Given this list of marker genes ARFGEF1, TRPM7, MYL3, CXCR4, RAB3B, STXBP5 (syntaxin binding protein 5), RAB39B, GIPC1, RAB11A, SPATA6L, RAB14, MYL12B, MYL2, MYBPC1 (NCBI Gene Id 9116), KIRREL1, STXBP5L, MYL9 (NCBI Gene Id 10398), MLPH, ACTA1, NPHS1, MYH8, RHOA, TRAK1, RAB3C, CALD1, RAB11B, CORO1A, TOM1, MYBPC3, MYO19, GCSAM, MYOC, MYLK2, TRAK2, GRIA1, PYCARD, RAB6B, VEZT, RAB25, NKD2, CALML4, TRIM32, SPATA6, HAP1, NPC1L1, DMD, MYL4, IQGAP3, SHROOM4, STX1A, ARFGEF2, LARP6, LLGL2, RAB3A (RAB3A, member RAS oncogene family), LIMCH1, MYL12A, RAB8A, GSN, ACTC1, RAB27A, USH2A, RAB27B, RALA, RAB3D, RAB10, RAB6A, MYRIP, SHROOM1, LLGL1, TRIOBP, SPTBN5, LMTK2, CNGA3, here is a description of the gene set: Human Gene Set: GOMF_MYOSIN_BINDING Binding to a myosin; myosins are any of a superfamily of molecular motor proteins that bind to actin and use the energy of ATP hydrolysis to generate force and movement along actin filaments. studied in species Homo sapiens